The following is a description of a gene set: Genes from the yellow module which are dn-regulated in HAEC cells (primary aortic endothelium) after exposure to the oxidized 1-palmitoyl-2-arachidonyl-sn-3-glycerophosphorylcholine (oxPAPC). Oxidized phospholipids are thought to promote atherogenesis by stimulating endothelial cells (ECs) to produce inflammatory cytokines, such as IL-8. In studies with mouse models, we previously demonstrated that genetic variation in inflammatory responses of endothelial cells to oxidized lipids contributes importantly to atherosclerosis susceptibility. We now show that similar variations occur in cultured aortic ECs derived from multiple heart transplant donors. These variations were stably maintained between passages and, thus, reflect either genetic or epigenetic regulatory differences. Expression array analysis of aortic EC cultures derived from 12 individuals revealed that >genes were regulated by oxidized phospholipids. We have used the observed variations in the sampled population to construct a gene coexpression network comprised of 15 modules of highly connected genes. We show that several identified modules are significantly enriched in genes for known pathways and confirm a module enriched for unfolded protein response (UPR) genes using siRNA and the UPR inducer tunicamycin. On the basis of the constructed network, we predicted that a gene of unknown function (MGC4504) present in the UPR module is a target for UPR transcriptional activator ATF4. Our data also indicate that IL-8 is present in the UPR module and is regulated, in part, by the UPR. We validate these by using siRNA. In conclusion, we show that interindividual variability can be used to group genes into pathways and predict gene-gene regulatory relationships, thus identifying targets potentially involved in susceptibility to common diseases such as atherosclerosis. species: Homo sapiens Human Gene Set: GARGALOVIC_RESPONSE_TO_OXIDIZED_PHOSPHOLIPIDS_YELLOW_DN from publication Gargalovic PS, Imura M, Zhang B, Gharavi NM, Clark MJ, Pagnon J, Yang WP, He A, Truong A, Patel S, Nelson SF, Horvath S, Berliner JA, Kirchgessner TG, Lusis AJ (PMID 16912112), and this is the list of marker genes: ZNF827, PCTP, ZNF18, HILPDA, PIK3R2, KNOP1, PATZ1, RGL1, B3GNT5, RGS3, PML, B4GALT5, GEMIN4, RNF145, DENND5B, OXLD1, SLC30A1, ZMYND8, LPCAT1, CCDC85B, RTL10 (retrotransposon Gag like 10), TMEM50B, NREP (NCBI Gene Id 9315)